The following is a description of a gene set: species: Homo sapiens Genes that comprise the mitochondria gene module A major goal of cancer research is to match specific therapies to molecular targets in cancer. Genome-scale expression profiling has identified new subtypes of cancer based on consistent patterns of variation in gene expression, leading to improved prognostic predictions. However, how these new genetic subtypes of cancers should be treated is unknown. Here, we show that a gene module map can guide the prospective identification of targeted therapies for genetic subtypes of cancer. By visualizing genome-scale gene expression in cancer as combinations of activated and deactivated functional modules, gene module maps can reveal specific functional pathways associated with each subtype that might be susceptible to targeted therapies. We show that in human breast cancers, activation of a poor-prognosis wound signature is strongly associated with induction of both a mitochondria gene module and a proteasome gene module. We found that 3-bromopyruvic acid, which inhibits glycolysis, selectively killed breast cells expressing the mitochondria and wound signatures. In addition, inhibition of proteasome activity by bortezomib, a drug approved for human use in multiple myeloma, abrogated wound signature expression and selectively killed breast cells expressing the wound signature. Thus, gene module maps may enable rapid translation of complex genomic signatures in human disease to targeted therapeutic strategies. from publication Wong DJ, Nuyten DS, Regev A, Lin M, Adler AS, Segal E, van de Vijver MJ, Chang HY (PMID 18199530) Human Gene Set: WONG_MITOCHONDRIA_GENE_MODULE, and this is the list of marker genes: NQO1, NFS1, AIFM1, COX6A1, GPD2, SLC25A32, CHDH, DCTN6, NME4, COX17, UQCRB, COX6C, COX7C, ATP5PO, ATP6V1C1, HSCB, MRPL3, MRPL27, NIPSNAP1, GOT2, GSTZ1, MRPL45, DAP3, ATP5F1E, NDUFA4 (NCBI Gene Id 4697), PDK3, SLC40A1, MRPL11, UNG, UQCR11, ATP5MC3, SURF1, ATP5MG, GLUD1, SLC16A5, ECI1, GPX4 (glutathione peroxidase 4), CLPP, NDUFA3, ATP6V1D, NDUFS4, ATP6AP1, GSTO1 (glutathione S-transferase omega 1), MRPS18C, PDHX, PDP1, NDUFA12, NDUFA1, FH, SDHB, MRPL36, MTX2, NDUFA7, KGD4, CRAT, ATP6V1G1, TOMM7, ACADSB, DLD, NDUFA9, PPIF, MRPS30, CYC1, NDUFV1, GIMAP5, MRPL18, ATP6V1B1, CP, BOP1, SFXN5, IDH2 (NCBI Gene Id 3418), BCL2, UQCR10, MRPL49, UQCRFS1, SUCLA2, TIMM8B, NDUFB1, COX4I1, TIMM10, SFXN2, GCDH, KARS1, ATP5PF, SEC61G, ATP6V1F, SCO1, GCAT, COX7B, MRPL40, SLC25A17, TFAM, HSD17B10, SCP2, TOMM70, TOMM40, ATP5ME, ACAT1, DIABLO, COX7A1, UQCRQ, NDUFC1 (NCBI Gene Id 4717), COX7A2, PDHB, COX5B, NDUFA10, MTRR, COX7B2, SLC25A39, MAOA, TSPO, ATP13A3, AGMAT, GATD3, AK2, MRPS18B, ABCB6, MIPEP, SOD2, CPT1A, NDUFS3, LONP1, ATP1B3, ATP5MC2, SLC9A2, HAX1, NDUFAF1, GSR, SLC16A3, PCCB, MRPS15, ATP5F1B, ATP5F1C, COX5A, FDXR, TIMM23, COX6B1, MCCC2, PTRH2, SLC25A19 (solute carrier family 25 member 19), OXCT1, CYB5A, AUH, ATP5PB, MTHFD2, MRPL13, NDUFS6, CRYZL1, FIBP, COX7A2L, DBT, VDAC3, TRIM45, TIMM13, NDUFC2, ALDH6A1, COQ3, COX11, SUCLG1, VDAC2, HCCS, TUFM, MRPS33, ATOX1, CYP27A1, ATP8A1, WARS2, SCO2, SLC25A22, NT5M, MRPS28, NDUFB10, NDUFS8, COX18, NDUFS2, PCK2, MCEE, GRPEL2, NDUFB2, ECHS1, HMGCS2, TSFM, DECR1, MRPS17, PRDX5, NDUFB4, MRPL42, NDUFB6, MCAT, SLC9A5, NDUFAB1, MRPS16, LRPPRC, CKMT1B, NDUFV2, ATP5MC1, CRYZ, HINT2, TIMM17B, MRPS18A, NDUFB5, COX8A, NDUFA5, DUT, NDUFB3, ATP5PD, ATP6V1E1, SLC25A1, NDUFA8 (NADH:ubiquinone oxidoreductase subunit A8), NDUFS5, NDUFA6, PDHA1, NDUFB9, MRPL32, ATP1B1 (NCBI Gene Id 481), MRPL12, NDUFB8, ATP5MF